The following is a description of a gene set: Human Gene Set: IRF1_Q6 studied in species Homo sapiens Genes having at least one occurrence of the motif TTCACTT in the regions spanning 4 kb centered on their transcription starting sites. This matches the IRF1 transcription factor binding site V$IRF1_Q6 (v7.4 TRANSFAC)., and this is the list of marker genes: NLK, SLC12A7, RRAGC, SNAI1, NUB1, PRKD2, NETO1, GADL1, MITF, IL18BP, GLRA1, FLI1, OSM, LY86 (lymphocyte antigen 86, NCBI Gene Id 9450), PITX2, ZNF296, PITX3, NKX2-1, CASZ1, CSRNP2, FIGN, CTSS, IL27, TBX6, ZMAT2, COL9A1, LAMC1, HLA-DQA1, DCDC1, BANK1, NRAS, IRS2, PDCD10, STAG1, SOX11 (SRY-box transcription factor 11), HGF, CCR7, OTP, NT5C3A, HTR3B, SIK3, NHLH2, PLXNC1, P4HA1, TENT4B, TUBD1, LSR, NDC1, ZBTB18, MSX1, MAB21L2, IFNL3, SIM1, ACSS2, BMF, HOXA10, LBX2-AS1, RET, OTX1, TCIRG1, IKZF2, DYRK1A, FOXN3, KLF6, AAMDC, GPBP1L1, PCDH9, DAPP1, NEDD4, SORBS1, PYM1, ERBB2, ASPA, TNFRSF19, TIA1, KYNU, TNFSF13B, MBNL1, PDZRN4, ARHGAP5 (Rho GTPase activating protein 5), PPM1D, EZR, GPR65, NUFIP2, FNTB (farnesyltransferase, CAAX box, subunit beta), ZMPSTE24, PIAS1, TYR, CACNA1C, ZBTB20, PPP1R12C, MEF2C, SKIDA1, RNF31, MMP13, KIF3A, SYNE2, MSS51, DPP10, MAB21L1, LIN28A, ZNF385A, FCGR2C, ADORA3, HNRNPA2B1, ENPP6, PKIG, HPCAL1, PTGR3 (prostaglandin reductase 3), PSME2, NCAM2, HOXB4, FEZF2, DDX17, ADAM15, MAP3K11, EDC4, ELMO3 (engulfment and cell motility 3), CALU, VAMP8, RSF1, CALD1, BRD9, NFAT5, YRDC, TBCC, CBX3, SERPINI1, LMO4, THRB, TAPBP, NR3C2, LUC7L3, TTC17, ZBTB37, FES, PPARGC1A, CDH6, HOXD13, CYRIA, WASF2, EHD1, FEV, GFRA3, RCOR1, ITGB7, IFNL2, MEGF11, TYROBP, TAPBPL, ATP2B1, STX16, FOXG1, CNOT4 (CCR4-NOT transcription complex subunit 4), DGKA, TCF15, SCRT2, LINC00314, ATP6V0D1, SLC26A6, EPN2, DSPP, HSCB, PSMB10, TMPRSS5, CUL2, EPS8, SREK1, CIAO2B, RIOK3, RAC1, FGB, PCDHGC3 (protocadherin gamma subfamily C, 3), SKP1, PHOX2B, ATP2C1, RPL23, ZSCAN20, BNIPL, TUG1, TNRC6A (trinucleotide repeat containing adaptor 6A), JARID2, PRKCB, PRMT3, NRXN3, MICU1, LYSMD2, PTMA, EBF1, BMP5, SNTB2, GFI1, LOX, KRT8P41, USP32, LMX1A, HLA-C, TRAPPC13, CEP120, PRICKLE2, ADAM23, LRRC39, NAPB, UGGT1, SIPA1L1, FCGR2B, RPS19, RBCK1, MS4A1, DDX39B (DExD-box helicase 39B), SOX14, B3GALT2 (NCBI Gene Id 90195), PLS1, EIF4A2, DLG2, VGLL4, ARAP1, RPA2, MYL3, ESRRG, SEMA5B, CIITA, TRIP13, ZRANB1, PAIP2, QKI, CNIH1, C1orf122, GRID2, TOGARAM2, TRIM23 (tripartite motif containing 23), MDGA2, USF1, CD53, CES2, SLC4A2, LSP1, PSMB3, TRIM21, RAD1, SGK1, ELAVL4, HOXA13, UBD, PHF21A, EMX2, WNT5A, CTNND2, FGF12, LINC02724, PCDHB1, CD37, GSX1, LRRC37BP1, RBM39, PAX6, GUCY2C, TBX1, PROX1, DLX1, CDX1, VDAC2, ZEB2